The following is a description of a gene set: Any process that modulates the propensity of RNA molecules to degradation. Includes processes that both stabilize and destabilize RNAs. Mouse Gene Set: GOBP_REGULATION_OF_RNA_STABILITY studied in species Mus musculus, and this is the list of marker genes: Gdnf, Gigyf2, Nanos3, Zcchc17, Rbm38, Larp1, Fastkd1, Vegfa, Hnrnpu, Angel2, Senp1, Mex3d, Zc3h14, Pan3, Rc3h1, Dhx9 (DExH-box helicase 9), Pum1, Elavl1, Slfn2, Fastk, Zc3h12d, Mapkapk2, Fam76b, Nsun2, Cnot6l, Zc3h12a, Ythdf2, Hnrnpa0, Tnfrsf1b, Mettl14, Lsm1, Pcid2, Traf5, Parn, Meioc, Larp4b, Cnot7, Nlrp5, Dcps, Piwil2, Noct, Upf1, Mir196a-2, Fastkd2, Dxo, Igf2bp3, Boll, Il17a, Tirap, Zfp36l1, Carhsp1, Rock2, Zfp36, Ago1, Dcp1a, Pnpt1, Tent5d, Nicol1, Ptbp1, Hnrnpc, Calcr, Srsf1, Cpeb3, Taf15 (NCBI Gene Id 70439), Cirbp, Mettl16, Samd4b, Ythdf1, Tent4b, Plekhn1, Phax, Tnrc6a, Cnot3, Apobec1, Trdmt1, Mir196b, Tnrc6c, Fto (NCBI Gene Id 26383), Pabpc1 (NCBI Gene Id 18458), Fastkd5, Lin28b, Pum2, Zar1, Nrde2, Igf2bp1, Dcp1b (NCBI Gene Id 319618), Rbm33, Naf1, Hnrnpr, Tent5b, Piwil4, Mtor, Secisbp2, Tent5c, Zfp36l3, Dicer1, Mir466l, Tut7, E2f1, Celf1, Pias4, Tut4, Rbm47, Brf1, Pan2, Rbm24, Tnrc6b, Ythdf3, Samd4, Vip, Elavl4, Cnot8, Rock1, Tnf, Tent4a, Thrap3, Dhx36, Qki, Ikbke, Fxr1, Mir451a, Fmr1, Ybx1, Myd88, Paip1, Mir451b, Patl1, Apex1, Piwil1, Tent5a, Tbrg4, Ang, Csde1, Ago2, Khsrp, Slc11a1, Hnrnpd, Pabpc4, Scgb1a1, Zc3h18, Mir196a-1, Patl2, Csdc2, Pnldc1, Pde12, Fus, Hnf4aos, Pabpn1l, Traf3ip2, Arid5a, Npm1, Ago3, Rbm10, Igf2bp2, Cnot1, Traf2, Rida, Mov10, Mlh1, Dis3l2, Sgms1os1, Eif4enif1, Mettl3, Dkc1, Trim71, Polr2g, Tardbp, Ybx2, Rnasel, Nanos1, Rc3h2, Ddx49, Dazl, Cnot2, Zfp36l2, Mir144, Nanos2, Mettl1, Cacng7, Cnot6, Dnd1, Pcbp4, Btg2, Vim, Alkbh5, Fxr2, Rbm46, Gtsf1, Fastkd3, Tob1, Caprin1, Dcp2, Axin2, Syncrip